The following is a description of a gene set: Mouse Gene Set: GOBP_EPIDERMIS_DEVELOPMENT species: Mus musculus The process whose specific outcome is the progression of the epidermis over time, from its formation to the mature structure. The epidermis is the outer epithelial layer of an animal, it may be a single layer that produces an extracellular material (e.g. the cuticle of arthropods) or a complex stratified squamous epithelium, as in the case of many vertebrate species., and this is the list of marker genes: Hes5, Sod1, Sprr2b, Naglu, Wnt10a, Pafah1b1, Tecta, Sprr3, Cldn1, Spint1, Hey1 (hairy/enhancer-of-split related with YRPW motif 1), Ncor1, Krt79, Zfp750, Foxq1, Krtap6-2, Kif3a, Srsf6, Rbpj, Pou2f3, Slc39a2, Ugcg, Sfn, Gsdma3, Flg, Sec24b, Atoh1, Pphln1, Tmprss11f, Lgr4, Kcnq1, Scrib, Krt72, Ppara, Gnas (NCBI Gene Id 78290), Alox8, Stfa1, Fzd3, Lrp4, Trp63, Pkp3, Nom1, Fuz, Plod1, Dll1, Pcdh15, Reg3g, Mfsd12, Stfa3, Igfbp5, Sprr2e, Wnt16, Lce1g, Ovol2, Inhba, Grhl3, Krt84, Reg3a, Alox12, Elovl1, Sprr4, Stfa2l1, Madcam1, Alg10b, Sprr2i, Ush1c, Cdkn2a, Atp7a, Lhfpl5, Ovol1, Abca12, Evpl, Cldn13, Egfr, Pls1, Atp2b2, Msx2, Fgf7, Tprn, Cdsn, Ift172, Grhl1, Lama5, Alox12b, Lce1a2, Krt14, Insr, Nherf1, Pax6, Fermt1, Il18, Hoxa7, Sharpin, Hrnr, Pou3f1, Med1, Snai1, Psap, Pias4, Ybx1, Krt2, Txnip, Cstdc4, Bmp4, Gli2, Tgm3, Akt1, Gm5478, Klf7, Irf6, Anxa1, Ercc2, Exph5, Ncor2, Krt71, Tgm1, Rela, Myo3b, Stfa2, Krt4, Ptprq, Sprr1a, Nsun2, Ppl, Hoxc13, Extl3, Mafb, Numa1, Krt27, Lgr5 (NCBI Gene Id 14160), Pnpla1, Clrn1, Eda, Sgpp1, Krt77, Ptgs2, Tmem79, Hes1, Nsdhl, Cux1, Rest, Myo3a, Apc, Krt73 (NCBI Gene Id 223915), Ppard, Intu, Tnf, Ngfr, Pkp1, Fgfr2, Gprc5d, Vangl2, Dkk4, Krt16, Gak, Mreg, Kcnma1, Krt76, Yap1, Grhl2, Krt81, Cstdc5, Wnt10b, Dbi (NCBI Gene Id 13167), Opn3 (NCBI Gene Id 13603), Trpv1, Tmprss13 (transmembrane protease, serine 13), Dsg4, Tfap2c, Fgf20, Bcr, Casp3, Map2k1, Mir450b, Aloxe3, Ppp3ca, Sfrp4, Norad, Stk4, Barx2, Sox21, Zdhhc21, Fst, Gli1, Dsp, Zfp36l1, Tsg101, Gorab, Macroh2a1, Ntf3, Mysm1, Lncpint, Kprp, Tmem132e, Grxcr2, Notch1, Krtap6-5, Dsc1, Sox9, Plod3, Psen1, Mycl, Celsr1, Il17a, Pla2g10, Maff, Nfkbiz, Slc44a4, Krt5, Cst6, Macroh2a2, Nf1, Flg2, Loricrin, Cdh3, Scel, Slc4a7, St14 (suppression of tumorigenicity 14 (colon carcinoma)), Ap3b1, Ldb1, Tmc1 (transmembrane channel-like gene family 1), Clic5, Shh, Trps1, Runx3, Cers3, Slc39a7, Grxcr1, Cldn4, Keap1, Csta2, Krt78, Atp2c1, Alx4 (NCBI Gene Id 11695), Ankrd24, Rock2, Krt25, Tnfrsf19, Srf, Krt90, Sos1, Ezh2, Cdh23, Ovol3, Mcoln3, Edaradd (EDAR associated via death domain), Tradd, Tomt, Gab1, Klk14 (NCBI Gene Id 317653), Krt82, Sprr1b, Krt80, Spink5, Gfi1, Mir96, Agpat2, Clrn2, Bcl11b, Csta1, Foxi3, Esrp1, Myo6 (NCBI Gene Id 60360), Mycn, Igf1r, Sprr2d, Krt1, Prss8, Runx1, Ush2a, Foxc1, Ldb2, Krt83, Sprr2g, Whrn, Gsdme (gasdermin E), Plec, Lats1, Pdgfa, Krt74, Fgf10, Epha2, Jag2, Etv4, Krt36, Ift74, Errfi1, Triobp, Dnase1l2, Stmn1, Nme2, Ubn1, Sprr2f, Lsr, Ncoa3, Fgf2 (NCBI Gene Id 14173), Myo7a, Cnfn, Gal, Sox18, Mafg, Cstdc6 (NCBI Gene Id 100038854), Krt6a, Krt17, Klf4 (NCBI Gene Id 269540), Zmpste24, Hdac1, Smarca4, Cyp27b1, Fosl2 (NCBI Gene Id 14284), Flnb, Edar, Vdr, Krt7, Svep1 (NCBI Gene Id 80647), Tfap2a, Ext1, Rac1, Col6a1, Lats2, Sprr2k, Smad4 (NCBI Gene Id 28063), Krt28 (keratin 28), Stard7, Palld, Pdzd7, Smo, Cd109, Aldh3a2, Krt6b (keratin 6B), Pum2, Foxn1, Prkch, Cysrt1, Asah1, Ptch1, Il1a, Sav1, Met, Ctsl, Fa2h, Ptch2, Tgfb2, Gata6, Apcdd1, Ntf5, Satb1, Ptgs1, Fgfr1, Kazn, Elapor2, Tfdp1, Krt87, Sostdc1, Myo5a, Rock1, Sprr2h, Ivl, Krt75, Cdh1, Pou4f3, Fzd6, Fgfr3, Jag1, Gdf3, Krtdap, Nab2, Krtap21-1, Zfp36, Sult2b1, Acer1, Clic4, Foxe1, Hdac2, Hdac3, Ripor2, Ercc3, Gm5414, Psen2, Csta3, Slitrk6 (SLIT and NTRK-like family, member 6), Cyp26b1, Gba1, Lhx2, Pou3f2, Ctnnb1, Strc, Wdpcp, Minar2, Ift88, Bcl2, Cstdc3, Hpse, Lamc1, Krt10, Mansc4, Wnt5a (wingless-type MMTV integration site family, member 5A), Fam3c, Dlx3, Dkk1, Krt85, Hey2, Nab1, Trpc4ap, Acvr1b, Elmod3, Krt86, Kdf1, Cdkn1a, Dicer1